The following is a description of a gene set: from publication Kanzawa T, Zhang L, Xiao L, Germano IM, Kondo Y, Kondo S (PMID 15592527) Arsenic trioxide (As(2)O(3)) has shown considerable efficacy in treating hematological malignancies with induction of programmed cell death (PCD) type I, apoptosis. However, the mechanisms underlying the antitumor effect of As(2)O(3) on solid tumors are poorly defined. Previously, we reported that As(2)O(3) induced autophagic cell death (PCD type II) but not apoptosis in human malignant glioma cell lines. The purpose of this study was to elucidate the molecular pathway leading to autophagic cell death. In this study, we demonstrated that the cell death was accompanied by involvement of autophagy-specific marker, microtubule-associated protein light chain 3 (LC3), and damage of mitochondrial membrane integrity, but not by caspase activation. Analysis by cDNA microarray, RT-PCR, and Western blot showed that cell death members of Bcl-2 family, Bcl-2/adenovirus E1B 19-kDa-interacting protein 3 (BNIP3) and its homologue BNIP3-like (BNIP3L), were upregulated in As(2)O(3)-induced autophagic cell death. Exogenous expression of BNIP3, but not BNIP3L, induced autophagic cell death in malignant glioma cells without As(2)O(3) treatment. When upregulation of BNIP3 induced by As(2)O(3) was suppressed by a dominant-negative effect of the transmembrane-deleted BNIP3 (BNIP3 Delta TM), autophagic cell death was inhibited. In contrast, BNIP3 transfection augmented As(2)O(3)-induced autophagic cell death. These results suggest that BNIP3 plays a central role in As(2)O(3)-induced autophagic cell death in malignant glioma cells. This study adds a new concept to characterize the pathways by which As(2)O(3) acts to induce autophagic cell death in malignant glioma cells. Human Gene Set: KAN_RESPONSE_TO_ARSENIC_TRIOXIDE species: Homo sapiens Genes changed in U373-MG cells (malignant glioma) upon treatment with arsenic trioxide, a chemical that can cause autophagic cell death., and this is the list of marker genes: MYBL1, AK4, DIRAS3, SOCS2, ADM (adrenomedullin), KCTD12, FABP4, IGFBP5, PSAT1, SPANXB1, BOP1, PLK2, ENO2, MT1X, ANKRD1, ARL4C, RGS4, PTPRZ1, TSC22D3, SCG2, PIMREG, DCBLD2, SLC7A11, NUPR1, SCD, ARHGAP6, C6orf15, SERPINE1 (serpin family E member 1), PTHLH, FEZF2, CBS, GDF15, PHGDH, HSPA1A, MT1G, GRN, HMOX1, MT1F, PDGFRA, MT1H, ARHGAP29, IGF2BP3, PTN (pleiotrophin), CXCL14, CRYAB, SEL1L3, GSTM3, TOP2A, IL7R, VCAN, LMNB1, HSPA6, GLRX, PIR, NES, ZNF512B, DPYSL3, PPP1R15A (protein phosphatase 1 regulatory subunit 15A), JAG1, RRM2 (ribonucleotide reductase regulatory subunit M2), JUN, KIF20A, THBS1, STC1, FAM162A, KLF12, TRIB3, AKR1C1, TRIM16 (tripartite motif containing 16), SOX2 (SRY-box transcription factor 2), GABARAPL1, MGP, PODXL, IL11, SPC25, INSIG1, SLC30A1, VAT1, MAP1LC3B, WIPI1, SACS, NDP, CTH, ID2, RIT1, MCM7, LDLR, HSPA1B, MT-ND5, EFNB2, GPNMB, GPR65, AKR1C3, MT1E, MT2A, HEY1, NAP1L1, FABP7, DDIT4, MYCNOS, AKR1B10, DDIT3, ATF3, BNIP3L, CXCL8, DKK1, SPANXA1, SLC12A1, TMEM158, FBXO5, EIF4G1, STC2, GFPT2, CAV2, ASNS, NDRG1, GPM6B, CCPG1, LGALS8, DLGAP5, CLEC2B, NOX1, SLC2A3